Given this list of marker genes SPOCK2, SLC39A2 (NCBI Gene Id 29986), DYRK2, SNRK, ITM2A, RAB11A, PIAS2, HAUS3, LRRC46, ZSWIM4, LUZP1, CXCR5, PHF6 (PHD finger protein 6), RBBP4, TOP3A, ANP32A, ANKRD2, FILIP1L, NSUN2, BMPR2, PARP12, SERPINB6, DGKA, RNF138, TSC22D3, CEP112, CCL22, RABGAP1L, ARID3B, MAP4K3, RAPGEF6, DBR1, EGR2, DIAPH1, MCL1, NUP88, GRAMD2B, CASP9 (caspase 9), HAUS6, CREBL2, PHF3, KIAA0586, CEMIP, PFN2, ARFGEF1, DCK, EIF4A2, DDX60, TEC, CCDC82, TRIM13, R3HDM1, NUF2, CBR4, APC2, RALGAPA1, OAS1 (NCBI Gene Id 4938), XIAP, RNF19A, UBLCP1 (ubiquitin like domain containing CTD phosphatase 1), SH2D1A, AP1S2, APOBEC3B, C2CD3 (NCBI Gene Id 26005), PCDHB7, ZNF770, FLII, MGAT4A, NFYC, TMEM130, ATP11C, MYB, LAMC2, ERGIC2, IKZF3, NOD1, LSM14A, DGKQ, TRAF1, FGF13, NR3C2, CFAP418, PDRG1, FGF9, CTNNA1, COL4A4 (NCBI Gene Id 1286), KCNQ5, MED12, ADIPOR1, ADGRF1, FNBP1L, TSGA10, H1-6 (H1.6 linker histone, cluster member), ECI2, CACNA1S, CAMTA1, GCA, SLAMF6 (SLAM family member 6), RNF130, CBLB, TOE1, XRN1, RNF44, HS2ST1, SCAMP1, BAZ2B, SLC25A13, BHLHE40, NBDY, VWA5A, CHD6, LSM3, CHIC2, BEX2, ANKRD34B, MAGEB5, KIDINS220, C4BPB, KIAA1191, FAM111A (NCBI Gene Id 63901), CRYGN, DNAJC1, PREX1, DNM1L, CNRIP1, ATP6V1B2, ZNF846 (NCBI Gene Id 162993), STK39, GPR63, STK4, IDE, PHC1, TNFAIP3, UVRAG, TRIM26, OTUD4, EXOC4, EPC2, NT5C3A, MYEF2, RHOU, YTHDC1, GADD45G, GLYAT, SNX13, SETD4, HNRNPA2B1, INTS7, CRTC2, SENP2 (NCBI Gene Id 59343), VOPP1, KBTBD2, RGS1, TXNIP, HERC4, HOMER1, KATNB1, TCF7, PHIP, CIBAR1, MSL2, ANKRD17, SON, DAZ2, RIPK4 (NCBI Gene Id 54101), RNF14, PLAAT3 (NCBI Gene Id 11145), DCP1A, SAP30, PFN3, CD69, SEC24B, HSPB9, B3GNT5, SOD1, RBL1, HERPUD2, MEGF9, CLCA2, BZW2, PPP1R15A, MACO1, ABTB2 (ankyrin repeat and BTB domain containing 2), DNAJB6, BEX3, BEX1, ADAD1, ABCG1, VPS54, ZNF394, MICALL2, ARHGAP15, PLSCR4, SLC25A36, AVL9, SENP6, BTLA, PDIA3, LUZP2, MAIP1, here is a description of the gene set: species: Homo sapiens Human Gene Set: GSE2770_TGFB_AND_IL4_VS_TGFB_AND_IL12_TREATED_ACT_CD4_TCELL_6H_DN from publication Lund R, Aittokallio T, Nevalainen O, Lahesmaa R (PMID 14607935) Genes down-regulated in CD4 T cells activated by anti-CD3 and anti-CD28: TGFB1 and IL4 (6h) versus TGFB1 and IL-12 (6h). Th1 and Th2 cells arise from a common precursor cell in response to triggering through the TCR and cytokine receptors for IL-12 or IL-4. This leads to activation of complex signaling pathways, which are not known in detail. Disturbances in the balance between type 1 and type 2 responses can lead to certain immune-mediated diseases. Thus, it is important to understand how Th1 and Th2 cells are generated. To clarify the mechanisms as to how IL-12 and IL-4 induce Th1 and Th2 differentiation and how TGF-beta can inhibit this process, we have used oligonucleotide arrays to examine the early polarization of Th1 and Th2 cells in the presence and absence of TGF-beta after 0, 2, 6 and 48 hours of polarization.